The following is a description of a gene set: Genes down-regulated in comparison of ex vivo CD8 dendritic cells versus cultured CD8 DCs. Human Gene Set: GSE339_EX_VIVO_VS_IN_CULTURE_CD8POS_DC_DN The functional relationships and properties of different sub-types of dendritic cells (DC) remain largely undefined. We used a global gene profiling approach to determine gene expression patterns among murine splenic CD11c high DC subsets in an effort to better characterise these cells. from publication Edwards AD, Chaussabel D, Tomlinson S, Schulz O, Sher A, Reis e Sousa C (PMID 12816982) studied in species Homo sapiens, and this is the list of marker genes: PTK2, AANAT, NCS1, LARP1, ATP5F1A, IFITM2, ATP9A, TSN, GADD45B, SERPINB9, TRAF3, SLN, ZC3H12C, NFKBIB, ARF4, IFIT1B, BHLHE40, DPM2 (dolichyl-phosphate mannosyltransferase subunit 2, regulatory), LDLR, MIF4GD, TRIM25, ZNFX1 (NCBI Gene Id 57169), SATB1, FKBP1A, UBXN4, NDEL1, RALA, TNNT3, CSF2RB, EMD, GJC1, ACOD1, ZIC3, IRGM, SNX4, LPCAT3, ADPRH, RGS9, CAPG, ANXA5, TENT5C, GJA5, ANTXR2, CLCN2, TOR1AIP2 (NCBI Gene Id 64163), C6orf120, M6PR, RAB12, PIK3R1, VCP, MOV10 (NCBI Gene Id 57723), SEMA7A, ELL2, BCL2L11 (NCBI Gene Id 150819), ETF1, SERPINI1, ARIH2, NUDT9, PPL, MOCOS, DDX50, PIH1D1, NPC1, RELA (NCBI Gene Id 5970), ARL4C, FBXW11 (F-box and WD repeat domain containing 11), LPIN2, BMP8B, KCTD10, ARHGEF3, STAT4, H2AZ1, GNA13, TRAF2, OPN1SW, TRIM3, ULK2, PKIB, EXT1, SMAP2, ART5, ARL2BP, ULK1 (NCBI Gene Id 8408), LITAF, FYN, SLC6A6, GABRB3, BIN1, FOXP1, TNFRSF1B, TNFSF9, USF2, RAB8B, NFKBIA, NPY2R, AEBP2, ADORA2A, HSPA5, TGIF1, LRRC59, MYD88, PEX5, GPD2 (glycerol-3-phosphate dehydrogenase 2), SPECC1, NFKB2, IST1, SLC25A20, CYTIP, STX3, LMNA, APOB, NR4A2 (nuclear receptor subfamily 4 group A member 2), PLEKHA7, ITGAV, TNFRSF1A, PAX3, MSH3, PTGIR, PTGER4, ANXA10, CCNA1, USP18, MERTK, SF1 (splicing factor 1), CD83, MXI1, ISG15, HOMER3, CYTH1, VAPB, RNF19B, SRCAP, MDH1, TACSTD2, TEC, FNDC3A, XRCC5, TRAF1, TIMM17B, TSPO, JUP, TMEM131, CMIP, CD80, CMTR1, EHD1, EBF2, CLDN1, CMPK2, PHC2, ACR, CXCL3, DGAT1, TSSC4, IFRD1, NPNT, TWSG1, TBC1D15, ARL1, CTNNA1, SLC5A1 (solute carrier family 5 member 1), MAP2K3, MMP11, ATP6V0C, SOWAHC, LAMC2, SLC3A2, BCL3, CDKN1A, PSMD11 (proteasome 26S subunit, non-ATPase 11), SNRPB, MAFK, WSB2, SPP1, PENK, KPNA1, TIPARP, DTX1, NDUFC2, HIVEP2, ATP6V1A, PTPN23, PEPD, XBP1, GABARAPL1, TNIP1, B3GALT1, MAPK6, HDC, BAIAP2, ESD, FABP4, POR, NBN, PLEC (plectin), RORA, PITPNB, CNOT4, SMS, SLC35B2